The following is a description of a gene set: studied in species Homo sapiens Human Gene Set: REACTOME_SMOOTH_MUSCLE_CONTRACTION Smooth Muscle Contraction, and this is the list of marker genes: MYL6B, MYL10 (NCBI Gene Id 93408), ANXA2, DYSF, SORBS3, ACTG2 (NCBI Gene Id 72), ITGA1, MYH11, PDE5A, GUCY1A1, GUCY1B1, MYL6, TLN1, MYL5, CACNA1H, ANXA1, ACTA2, TRIM72, TPM4, MYL12A, ANXA6, ITGB5 (NCBI Gene Id 3693), PAK2, SORBS1, GUCY1A2, CAV3, TPM3, TPM1, LMOD1, MYL11, MYL9, CALD1, MYL7, ALDH2, CACNA1I, CALM1, MYLK, VCL, TPM2, CACNA1G, MYL12B, PAK1, PXN